Given this list of marker genes 9430065F17Rik, Cenpl, Rprd2, Odc1, Nmnat2, Rhno1, Limk2, Pstk, Dars2, Wars1, Usp37, Mylip, Cstb, Tmem63c (NCBI Gene Id 217733), 1700021P04Rik, Ranbp17, Arap1, Abhd8, Zfp961, Slco4c1, 1700041I07Rik, Gm2673, Inpp5d, Rfwd3, Itgb1, Rnpep, Sugct (NCBI Gene Id 97907), Naa25, Chchd4, Lnpk, Mplkip, Cxcl11, Rdh10 (retinol dehydrogenase 10 (all-trans)), 4930445N08Rik, Foxm1, Tmem43, Atf7ip, Bscl2 (NCBI Gene Id 67517), Lamc1, Ints8, Ctu1, Gdi1, Pdgfra, Fubp3, Zfp748, Mmachc, Panct2, Hccs, Stxbp5l, Serpine1, Atp6v1f, Dhodh, Zfp560, Gm15246, Scfd1, Slc8a2, Wdr25, Pmaip1, Rangrf, Ythdf2, Tax1bp1, Fhdc1, Etfrf1, Alkbh4, Zfand5, Arhgap45 (NCBI Gene Id 70719), Cyp51, Pcyt2, Ttk, Utp15, Lrwd1, Nudt18, Gls, Tet2, Usp12, Tulp2, AA465934, Ccdc163 (NCBI Gene Id 71260), Yjefn3, Vrk3, Nup205, Dnai7, Tmc4, 4833407H14Rik, Sptlc2, LTO1, Hnrnph1, Tgds, Zfp473, Cilp2, Malsu1, Timm50, Dync2i2, Ndufa13, Eef2, here is a description of the gene set: studied in species Mus musculus Mouse Gene Set: GM14401_TARGET_GENES from publication Yevshin I, Sharipov R, Kolmykov S, Kondrakhin Y, Kolpakov F (PMID 30445619)